Given this list of marker genes FGFR1, ASXL3, GPR135, ORAI2, SCNN1A, CBX6, MED12L, MBD2, NUDCD1, RAB11FIP2, INKA2, PLCH1, MMACHC, PI4KB, ELAVL3, ATP6V1G2, ZBTB39, PKNOX2, CYYR1, TBR1, TMTC3, TPP1, LOXHD1, ZNF629, GRIK1, ERFE, BRAF, SERAC1, CSNK1A1, YY1AP1, TMX4, CLCF1, SLC38A1, TAF1, RXRG, TAB3 (TGF-beta activated kinase 1 (MAP3K7) binding protein 3), S1PR3, TBC1D8B, CFLAR, SUCNR1, PDE8B, SH3BP4, ZFHX4, NAALADL2, TLN1, PRLR, CLIP3, PIK3CA, CCDC82, OPN5, RSAD2, USP14, LMO7, NLN, PDE12, MAP1A, CYBB, PSTPIP2 (NCBI Gene Id 9078), PYGB, ZNF750, TRPC5OS, KAZALD1, IGF2, SUSD2, TMEM144, ARGFX, ANKRD26, CNIH3, ZNF470, IL6ST, ACSL1, G3BP1, PIK3R3, PLEKHS1, GOLT1A, NECTIN2, CEP135, APOL4, OSBPL6, ANXA1, NPFFR2, AMIGO1, ADGRA3, LUC7L3 (NCBI Gene Id 51747), ELK1, ELOVL4, ABCB7, SLC25A23, PRICKLE4, C3orf36, RHOC, YES1, PLAA, HECTD3, MARCKSL1, CCDC97 (NCBI Gene Id 90324), BNC2, ST8SIA1, RICTOR, PRKCB, G3BP2, GDF11, AFF3, MCTS1, PURG, BCAM, PKP2, CXCL11, C1QTNF3, ATP2B4, NME8, PCSK2, YY2, SSX2IP, TRAM1, PRH2, MED9, PPP1R9B, DIRAS2, NOS1, WFDC12, PATL1, SLC4A10, PSKH1, ZNF32 (zinc finger protein 32), GBP3, DCTN4, ZDHHC8, MTF2, CD69, here is a description of the gene set: Genes predicted to be targets of miRBase v22 microRNA hsa-miR-450a-2-3p in miRDB v6.0 with MirTarget v4 prediction scores > 80 (high confidence targets). species: Homo sapiens from publication Chen Y, Wang X (PMID 31504780) Human Gene Set: MIR450A_2_3P